The following is a description of a gene set: Human Gene Set: HP_MITOCHONDRIAL_MYOPATHY Mitochondrial myopathy studied in species Homo sapiens A type of myopathy associated with mitochondrial disease and characterized by findings on biopsy such as ragged red muscle fibers., and this is the list of marker genes: NDUFB9, MT-ND4, NDUFS7, TMEM126B, MT-TT, NDUFS2, MSTO1, MT-TK, POLG, NDUFA11, MT-ND6, NDUFV2, NDUFAF3, POLG2, TIMMDC1, NDUFA1, OPA1, MT-CO2, DNA2, NUBPL (NUBP iron-sulfur cluster assembly factor, mitochondrial), NDUFV1, NDUFS6, SLC25A4, PNPLA8, PUS1, NDUFB11 (NCBI Gene Id 54539), NDUFB3, NDUFB10, NDUFS1, MT-CO1, NDUFA6, MT-ATP6, TK2, MT-TW, MT-ND5, NDUFS8, MT-ND3, FOXRED1, MT-TV, TYMP, MT-TF (mitochondrially encoded tRNA-Phe (UUU/C)), MT-TQ, MT-CYB, FDX2, NDUFS4, MT-ND2, NDUFAF8, MT-TS2, YARS2, AGK, NDUFAF4, CAV3, TWNK, MT-TC, MT-CO3, NDUFAF2, NDUFAF1, MT-ND1, NDUFAF5, RRM2B, ISCU, MT-TL1, NDUFS3